The following is a description of a gene set: Mouse Gene Set: GOBP_REGULATION_OF_SYSTEMIC_ARTERIAL_BLOOD_PRESSURE_BY_CIRCULATORY_RENIN_ANGIOTENSIN studied in species Mus musculus The process in which angiotensinogen metabolites in the bloodstream modulate the force with which blood passes through the circulatory system. The process begins when renin is released and cleaves angiotensinogen., and this is the list of marker genes: Ace2, Agtr1a (NCBI Gene Id 72294), Comt, Ace, Ednrb, Atp6ap2, F2rl1, Prep, Anpep, Mcpt4, Cpa3, Agt, Ren1, Enpep, Sucnr1, Mme, Or51e2, Ndst2, Cyp11b2, Agtr2, F2r, Prcp, Kcnn4, Gja5, Agtr1b